Given this list of marker genes Mab21l4, Gm829, Slc5a7, Cyp1b1, Prkca, Kcnj13, Sorcs2, Pcdha10 (protocadherin alpha 10), Dynll2, Pcdha1, Anxa5 (NCBI Gene Id 97115), Tmx4, Adam22, Pcdha5, Sash1, Pcdha8, Ppp2r2a, Pcdha11, Six2, Ago2, Nipal2, Rpusd2, Saa1, Lacc1, Irak3, Tmem169, Pcdha4, Cyp2f2, Becn1, Snx27, Pcdha6, Esp1, Rasl11b, Krtap4-13 (NCBI Gene Id 69464), Lrrn4, Vegfa, Ikbkb, St6gal1, Dusp16, Hnrnpa3 (heterogeneous nuclear ribonucleoprotein A3), Cln6, Sema3c, Acly, Lrguk, Adgrl2, Gpbp1, Ccdc39, Lyrm4, Nipal3, Taf9b, Mtmr2, Pcdha12, Trip4, Pcdhac1, Gjb5, Dscaml1, Ankrd44, Pcdhac2, Arih1, Wnt7a, Tbl1xr1, Pou4f2, Krtap4-21, Pcdh15, Pcdha2, Ttn, Papss2, Crebzf, Myocd, Tubgcp4, Mmp27, Bach2, Gm10778, Pycr1, Snx30, Mapk10, Tbc1d10b, Pcdha7, Pcdha9, Pla2g4c, Rit2, Pcdha3, Pld2, Nat8f4, Pcyt1b, Upp2, Sirt7, Aip, Mtcl2, Slc9a4, Adgrl4, Prr16, Faxc, Hoxc10, Tspan9, here is a description of the gene set: studied in species Mus musculus Genes predicted to be targets of miRBase v22 microRNA mmu_miR_741_3p in miRDB v6.0 with MirTarget v4 prediction scores > 80 (high confidence targets). Mouse Gene Set: MIR_741_3P from publication Chen Y, Wang X (PMID 31504780)